The following is a description of a gene set: Cytokines mediate cell-cell communication in the immune system and represent important therapeutic targets. A myriad of studies have highlighted their central role in immune function, yet we lack a global view of the cellular responses of each immune cell type to each cytokine. To address this gap, the authors created the Immune Dictionary, a compendium of single-cell transcriptomic profiles of more than 17 immune cell types in response to each of 86 cytokines (>1,400 cytokine-cell type combinations) in mouse lymph nodes in vivo. A cytokine-centric view of the dictionary revealed that most cytokines induce highly cell-type-specific responses. For example, the inflammatory cytokine interleukin-1β induces distinct gene programmes in almost every cell type. A cell-type-centric view of the dictionary identified more than 66 cytokine-driven cellular polarization states across immune cell types, including previously uncharacterized states such as an interleukin-18-induced polyfunctional natural killer cell state. from publication Cui A, Huang T, Li S, Ma A, Pérez JL, Sander C, Keskin DB, Wu CJ, Fraenkel E, Hacohen N (PMID 38057668) Mouse Gene Set: CUI_T_CELL_GD_IL10_RESPONSE_DN Genes negatively differentially expressed in cell type: γδ T cell upon treatment with cytokine: IL-10 in mouse lymph nodes in vivo. studied in species Mus musculus, and this is the list of marker genes: Btg2, Txk, Rgs1, Junb, Klf2, Cxcr4, Zfp36l2